Given this list of marker genes RPA2, BMAL1, PCNT, PTH1R, NRL, JDP2, CADM1, RHOBTB3, ZNF366, SEMA3C, HAS2, SCRT2, PIK3CA, XYLT2, KRT23, SDF2, FBLN2, NFYA, GABRG1, LRRC15, NPVF, CHN2, MSX2, MMP27, TAC1, MTSS1, SIAH3, COL4A4, MYL1, BHLHE41, NPR3, OSR2, SYTL5, JUNB, SLC37A4, FEV, CGA, LRP2, ANGPT1, NREP, TAF2, ST8SIA3, WNT8B, TFAP2A, ROBO1, KRTAP11-1 (keratin associated protein 11-1), UNC5B, PCNX1, MOSMO, BAZ1A, TRPM8, PCSK2, MED12L, DIXDC1, RREB1, H3-3B, DDX6, CNBD1, RAB22A, PITX2, DACH1, HOXD9, LINC00311, GTPBP1, GRPR (NCBI Gene Id 2925, gastrin releasing peptide receptor), LYSMD2, LMX1A, YRDC, GRM5, PRL, HERPUD2, RAPGEFL1, PXYLP1, PPP1R1B, NOTCH2NLA, IRX6, PRDM1, KCNH5 (potassium voltage-gated channel subfamily H member 5), LDB2, MYF6, TOB1, TSHZ3, SSPN, FIGN, NEO1, HOXC6, NOTCH2, FAM169BP, IRX4 (iroquois homeobox 4), KCTD15, ITPR3, MID1, KALRN (kalirin RhoGEF kinase), ELMO1, SHOX2, WNT9A, PDZRN4, PACSIN3, FKBP5, DSPP, NABP2, JPH3, CASZ1, ZBTB20, KLHL5, GSC, SRSF7, KCNMA1, TECTA, TMIGD1, C1orf122, ZBTB18, ID3, PPP2R2B, TMEM255A (NCBI Gene Id 55026), HOXA2, OARD1, CFB, OLFM4, NEUROD6, C1orf87, MARCKS, COLEC10, TNRC6A, RORB, ARHGAP44, PRR34, PART1, LRRTM1, LBX1, WDR49, SALL3, RGS12, STX7, SUPT6H, KLF7, CPA5, LEMD1, NOVA1, RARB, PIK3R3, SEMA6A, SLC24A4, TNFSF13B, HRK, ITGA8, CELF2, OFCC1 (NCBI Gene Id 285807), EPB41L5, SERTAD4, PCMTD1, CALN1, CYLD, ADAMTS17, FAM193B, TMEM179, RORA, ALDH1A1, OPRM1, DCX, FIP1L1, RAX, TYR, SIX1, TBX6, EN1, NKX6-1, KCNN3, PRKAB1, CXCL13, PRRX1, PRKG1, RBFOX1, TBX19, SRPK2, SULF2, TAFA1, RGS8, TFAP2D, SP8, CLRN1, GPR22, PCDH10, COL4A3, ADRB2, KCNS1, STAC2 (NCBI Gene Id 342667), TBR1, GNB3, VIL1, CDKL5, SULF1, TP63, TAAR5, GSE1, LINC00314, DCT (NCBI Gene Id 1638), DMD, KAT6B, NEBL, HESX1, FGF19, PHOX2B, KCP, BARHL1, RTN4RL1 (NCBI Gene Id 146760), PTPRO, NLGN2, RASL10B, LMO3, LUC7L3, KLF14, INPPL1, DLL4, LYG2, ZEB2, MBNL1, ZRSR2, KRT32, EBF2, PRKAR2A, TLE4 (NCBI Gene Id 7091), HHIP, SNTG1, NRP1, OTX2, NONO, GNAO1, DSG1, ADAM11, SP6, ARID3B, here is a description of the gene set: studied in species Homo sapiens Human Gene Set: LHX3_01 Genes having at least one occurrence of the motif AATTAATTAA in the regions spanning 4 kb centered on their transcription starting sites. This matches the LHX3 transcription factor binding site V$LHX3_01 (v7.4 TRANSFAC).